Given this list of marker genes CD24, CLCN6, NDC1, GPBAR1, REEP5, AKR1B10, BTRC, C20orf173, FANCC, TMEM183A, TMEM183BP, AKAP5, KCNE4, IGF2BP3, LAMTOR3, TIRAP, SELENOF, MRPL35, TIAM2, FGFR2, LFNG, NR2F1, KRTAP2-3, HTR7, ACP6, COG7, MBNL1, OR7A5, TMTC1, RABEP1, EIF4A2, SERPINB5, FARS2, GLRX, TCF7L2, GATAD2A (GATA zinc finger domain containing 2A), FZD4, ITK, SLC30A7, GRID2IP, NFE2L3, PPP3R1, here is a description of the gene set: Genes predicted to be targets of miRBase v22 microRNA hsa-miR-3151-3p in miRDB v6.0 with MirTarget v4 prediction scores > 80 (high confidence targets). from publication Chen Y, Wang X (PMID 31504780) species: Homo sapiens Human Gene Set: MIR3151_3P